The following is a description of a gene set: studied in species Homo sapiens Impaired proliferation and expansion of a T cell population following activation by an antigenic stimulus. Reduced antigen-specific T cell proliferation Human Gene Set: HP_REDUCED_ANTIGEN_SPECIFIC_T_CELL_PROLIFERATION, and this is the list of marker genes: PGM3, NSMCE3, CTPS1, DOCK2, LCP2, RAG1, RNF31, RFXANK, RAG2, CARD11